The following is a description of a gene set: species: Homo sapiens Human Gene Set: GOBP_POSITIVE_REGULATION_OF_MHC_CLASS_I_BIOSYNTHETIC_PROCESS Any process that activates or increases the frequency, rate or extent of the chemical reactions and pathways resulting in the formation of MHC class I., and this is the list of marker genes: HSPH1, NLRC5, CIITA, NLRP12, IL33 (NCBI Gene Id 90865), IFNL1